Given this list of marker genes Psma3, Pcsk7, H2bc1, Ost4, Psmc4, H4c6, Psmd6, Jup, Psmd7, H2ac19, H2bc8, Spcs1, H2bc7, Psmc2, H4c1, Mtbp, Ctss, H3c6, H3c13, H2bc9, H2ac15, Dad1, H4c17, Fyn, Cdh1, H4c3, H3c7, Kdm1a, H3c1, Pomt2, H4c14, Rps27a, H4c4 (H4 clustered histone 4), Psmd13, Psmc1, Psmc6, Psmd1, Spcs2, Pip5k1c, Pomt1, H2ac20, Psmb7, H4c12, Psma6, H2ac23, Ubb, H2bc13, H3c8, Rack1, H4c18, Psma7, H4c9, H2bc3, H2ac24, Psma4, Stt3a, H2ac11, Spcs3 (NCBI Gene Id 76687), H2ac1, H2ac22, Ddost, Ctnnb1, H4c11, H4c8, Dnm2, H2ac6, Rbbp7, H2ax, Dnttip1, Ganab, H2ac8, H4c2, Actg2, Psmd12, H2bc15, Prkcsh, Banp, Cbll1, H2ac4, Psmb4, Psma2, Psma5, Ezh2, H2ac13, Actc1 (NCBI Gene Id 11464), Tmem258, H3c15, H3c3, Psmc5, H3f3a (H3.3 histone A), H2bc11, H2ac10, H2bc22, Psma1, H3c4, H2bc12, Psmb5, Smarca4, Acta1, H3c11, Zmym2, Psmc3 (proteasome (prosome, macropain) 26S subunit, ATPase 3), H3c2 (NCBI Gene Id 319150), Twist1, Rbbp4, H2ac7, H2bc27, Csnk2b, Sec11c, H2ac12, Psmb6, H2az2, H3c10, here is a description of the gene set: electronically inferred by orthology from the curated human pathway species: Mus musculus Reactome Pathway: Regulation of Expression and Function of Type I Classical Cadherins part of: Regulation of Homotypic Cell-Cell Adhesion This event has been computationally inferred from an event that has been demonstrated in another species.<p>The inference is based on the homology mapping from PANTHER. Briefly, reactions for which all involved PhysicalEntities (in input, output and catalyst) have a mapped orthologue/paralogue (for complexes at least 75% of components must have a mapping) are inferred to the other species.